Given this list of marker genes FGF13 (NCBI Gene Id 730528), MYH11, ROBO1, RUNX1T1, HGF, here is a description of the gene set: Human Gene Set: VALK_AML_WITH_T_8_21_TRANSLOCATION BACKGROUND: In patients with acute myeloid leukemia (AML) a combination of methods must be used to classify the disease, make therapeutic decisions, and determine the prognosis. However, this combined approach provides correct therapeutic and prognostic information in only 50 percent of cases. METHODS: We determined the gene-expression profiles in samples of peripheral blood or bone marrow from 285 patients with AML using Affymetrix U133A GeneChips containing approximately 13,000 unique genes or expression-signature tags. Data analyses were carried out with Omniviz, significance analysis of microarrays, and prediction analysis of microarrays software. Statistical analyses were performed to determine the prognostic significance of cases of AML with specific molecular signatures. RESULTS: Unsupervised cluster analyses identified 16 groups of patients with AML on the basis of molecular signatures. We identified the genes that defined these clusters and determined the minimal numbers of genes needed to identify prognostically important clusters with a high degree of accuracy. The clustering was driven by the presence of chromosomal lesions (e.g., t(8;21), t(15;17), and inv(16)), particular genetic mutations (CEBPA), and abnormal oncogene expression (EVI1). We identified several novel clusters, some consisting of specimens with normal karyotypes. A unique cluster with a distinctive gene-expression signature included cases of AML with a poor treatment outcome. CONCLUSIONS: Gene-expression profiling allows a comprehensive classification of AML that includes previously identified genetically defined subgroups and a novel cluster with an adverse prognosis. from publication Valk PJ, Verhaak RG, Beijen MA, Erpelinck CA, Barjesteh van Waalwijk van Doorn-Khosrovani S, Boer JM, Beverloo HB, Moorhouse MJ, van der Spek PJ, Löwenberg B, Delwel R (PMID 15084694) studied in species Homo sapiens Genes that best predicted acute myeloid leukemia (AML) with the t(8;21) translocation producing the AML1-ETO fusion.